Given this list of marker genes GNA12, CNOT3, PTPN7 (protein tyrosine phosphatase non-receptor type 7), SLC7A6, IGHV3-69-1 (NCBI Gene Id 28402), SBNO2, SLC25A42, YKT6, IGHV3-23, UBTF, ZBTB48, TOMM40, POR, PKMYT1, STXBP2, ATOSB, PRKCSH, PTPN1, SASH3, HMGA1, VCP, EIF4G1, TK1, DVL1, VDAC1, CALR, TOP3B, CDK16, ARHGEF1, MYO9B, MLH1, BCR, SMG5, E2F4, SMARCD1, CLUH, PPT2 (palmitoyl-protein thioesterase 2), TYMS, ACTN4, SAFB, SRC, PPP5C, KCNAB2, PRRC2A, KDM5C, here is a description of the gene set: Genes up-regulated in samples from B-CLL (B-cell chronic lymphocytic leukemia) with the immunoglobulin heavy chain VH3-21 gene. Human Gene Set: FAELT_B_CLL_WITH_VH3_21_UP The usage of the immunoglobulin (Ig) V(H)3-21 gene is associated with poor prognosis in B-cell chronic lymphocytic leukemia (B-CLL) despite V(H) gene mutation status. Many V(H)3-21+ patients also display restricted heavy- and light-chain Ig gene rearrangements, implying a role of antigen selection in disease development. To explore the specific phenotypic/genotypic features among V(H)3-21+ B-CLLs, we compared gene expression patterns in 15 V(H)3-21+ and 24 non-V(H)3-21 patients (11 with unmutated and 13 with mutated V(H) genes) using Affymetrix microarray analysis (approximately genes). A distinct expression profile was identified for V(H)3-21+ patients in contrast to the Ig-unmutated and -mutated groups. By applying different algorithms, the data enabled an efficient class discrimination of the V(H)3-21+ subset based on 27 or genes. A set of genes was sorted out which, using different analytical methods, consistently gave a distinction between V(H)3-21+ and non-V(H)3-21 samples. Several of these genes are involved in regulation of DNA replication/cell-cycle control, transcription and protein kinase activity, which may render the V(H)3-21+ cells with a higher proliferative drive. However, no clear evidence of increased B-cell receptor signaling was found in the V(H)3-21+ group. Altogether, our identification of a specific V(H)3-21 profile may provide insights into the pathogenesis of the V(H)3-21+ subgroup. studied in species Homo sapiens from publication Fält S, Merup M, Tobin G, Thunberg U, Gahrton G, Rosenquist R, Wennborg A (PMID 15817677)